The following is a description of a gene set: Mouse Gene Set: GOBP_MESENCHYMAL_CELL_MIGRATION studied in species Mus musculus The orderly movement of a mesenchymal cell from one site to another, often during the development of a multicellular organism., and this is the list of marker genes: Sema4b, Sema3c, Bmp4, Smo, Ret, Bmp7, Sema6b, Sema4d, Phactr4, Nrp1, Sema4a, Ednrb, Tbx1, Tpbg, Sema6c, Nrtn, Sox8, Fn1, Sema3g, Gdnf, Eng, Ovol2, Cfl1, Folr1, Lama5, Sema3d, Gbx2, Fgf15, Sema5a, Sema6d, Pax3, Sema4g, Sema3a, Sema5b, Edn1, Twist1, Cdc42, Kitl, Cdh2, Htr2b, Sema4f, Radil, Coro1c, Sox10 (NCBI Gene Id 20665), Nrp2, Zeb2, Hif1a, Isl1 (NCBI Gene Id 16392), Sema4c, Sema6a, Sema7a, Pitx2, Sema3e, Phox2b, Sema3f, Acvr1, Shh, Sema3b, Ankrd11, Erbb4, Efnb1, Hand2, Ednra, Edn3, Pax6